The following is a description of a gene set: Catalysis of the reaction: peptidyl L-proline + 2-oxoglutarate + O2 = peptidyl trans-4-hydroxy-L-proline + succinate + CO2. species: Mus musculus Mouse Gene Set: GOMF_PEPTIDYL_PROLINE_4_DIOXYGENASE_ACTIVITY, and this is the list of marker genes: Egln1, Egln2, P4hb, P4ha1, Egln3, P4ha2, P4ha3, P4htm